Given this list of marker genes Stx4a, Vamp2, Cplx1, Epb41l1, Snap23, Snap47, Sacm1l (SAC1 suppressor of actin mutations 1-like (yeast)), Stx3, Stx1b, here is a description of the gene set: studied in species Mus musculus Mouse Gene Set: GOBP_EXOCYTIC_INSERTION_OF_NEUROTRANSMITTER_RECEPTOR_TO_POSTSYNAPTIC_MEMBRANE The exocytic fusion of neurotransmitter receptor containing vesicles with the postsynaptic membrane resulting in the integration of NT receptors, enabling them to participate in neurotransmitter reception. This process includes tethering and docking steps that prepare vesicles for fusion.